The following is a description of a gene set: Propensity for subsequent distant metastasis in head and neck squamous-cell carcinoma (HNSCC) was analysed using 186 primary tumours from patients initially treated by surgery that developed (M) or did not develop (NM) metastases as the first recurrent event. Transcriptome (Affymetrix HGU133_Plus2, QRT-PCR) and array-comparative genomic hybridization data were collected. Non-supervised hierarchical clustering based on Affymetrix data distinguished tumours differing in pathological differentiation, and identified associated functional changes. Propensity for metastasis was not associated with these subgroups. Using QRT-PCR data we identified a four-gene model (PSMD10, HSD17B12, FLOT2 and KRT17) that predicts M/NM status with 77% success in a separate 79-sample validation group of HNSCC samples. This prediction is independent of clinical criteria (age, lymph node status, stage, differentiation and localization). The most significantly altered transcripts in M versus NM were significantly associated to metastasis-related functions, including adhesion, mobility and cell survival. Several genomic modifications were significantly associated with M/NM status (most notably gains at 4q11-22 and Xq12-28; losses at 11q14-24 and 17q11 losses) and partly linked to transcription modifications. This work yields a basis for the development of prognostic molecular signatures, markers and therapeutic targets for HNSCC metastasis. from publication Rickman DS, Millon R, De Reynies A, Thomas E, Wasylyk C, Muller D, Abecassis J, Wasylyk B (PMID 18679425) Cluster b: genes identifying an intrinsic group in head and neck squamous cell carcinoma (HNSCC). Human Gene Set: RICKMAN_HEAD_AND_NECK_CANCER_B species: Homo sapiens, and this is the list of marker genes: PLAAT1, MAGEA2, ZNF738, DANT2, COMP (cartilage oligomeric matrix protein), UGT8, EYA4, SOST, CDKN2B, GPC3, SFRP4, CCDC144NL-AS1, ARHGEF26, COL11A1, MIR1245A (NCBI Gene Id 100302219), MAGEA11, OMD, SYT1, USP9Y, COCH, TXLNGY, PRSS21, CALML5, CDKN2A, HPS3, EIF1AY, MUC15, COL21A1, LINC01614, ELF5, CNTNAP2, PTH2R, NRXN3, GAGE1, MAGEA10, BCHE, HLA-DQA1, CT45A3, PNMA8A, GTSF1, MFAP5 (NCBI Gene Id 8076), LRRC17, MAGEA4, BBOX1, NRN1, NLRP2, TP53TG3, CLIC6, CSAG3, ZIC1, SPESP1, ENSG00000307470, MAGEA9, BEX1, IGSF11, OGN (osteoglycin), FAR2P2